Given this list of marker genes SLC25A17, ABCD2, PEX26, PEX13, PEX14, ALDH3A2, ABCD1, ABCD3, PEX11B, PEX19, PXMP4, GDAP1, FIS1, PEX3, PEX2, ACBD5, PEX12, PEX16, ATAD1, PXMP2, here is a description of the gene set: studied in species Homo sapiens part of: Protein localization Most peroxisomal membrane proteins (PMPs) are inserted into the peroxisomal membrane by the receptor-chaperone PEX19 and the docking receptor PEX3. PEX19 binds the PMP as it is translated in the cytosol. Recognition of the PMP by PEX 19 appears to depend on positively charged residues in the transmembrane domain of the PMP. The PEX19:PMP complex then interacts with PEX3 located in the peroxisomal membrane. Through a mechanism that is not yet clear, the PMP is inserted into the peroxisomal membrane and PEX19 dissociates from PEX3. A current model involves transfer of the PMP from PEX19 to a hydrophobic region of PEX3 followed by insertion of the PMP into the membrane. The process does not appear to require hydrolysis of ATP or GTP.<br>Unlike other PMPs, PEX3 is inserted into the peroxisomal membrane by binding PEX19 and then docking with PEX16. Both PEX3 and PEX16 can also be co-translationally inserted into the endoplasmic reticulum membrane. This region of the ER membrane then buds to contribute to new peroxisomes. PEX3 is also observed to insert into the mitochondrial outer membrane. Regions of the ER membrane and mitochondrial outer membrane are then released to form pre-peroxisomal vesicles which fuse to form new peroxisomes. Peroxisomes therefore appear to arise from fission of existing peroxisomes and production of new peroxisomes from precursors derived from mitochondria and the ER. Reactome Pathway: Class I peroxisomal membrane protein import